Given this list of marker genes Il17ra, Il1rl1, Il1rap, Tslp, Nlrp3, Il17rb, Gata3, Rara, Il33, Pde4d, Prkcz, Il9, Crlf2, here is a description of the gene set: studied in species Mus musculus Mouse Gene Set: GOBP_POSITIVE_REGULATION_OF_INTERLEUKIN_5_PRODUCTION Any process that activates or increases the frequency, rate, or extent of interleukin-5 production.